The following is a description of a gene set: Human Gene Set: MIR6752_5P studied in species Homo sapiens Genes predicted to be targets of miRBase v22 microRNA hsa-miR-6752-5p in miRDB v6.0 with MirTarget v4 prediction scores > 80 (high confidence targets). from publication Chen Y, Wang X (PMID 31504780), and this is the list of marker genes: P2RX1, NDFIP1, MECP2, TBC1D30, LZTS3, PIP5K1A, PCYT1B, PRKACA, TBKBP1, RAB2A, ZBTB7A, RUNX3, PRKCG (protein kinase C gamma), TTC9, CETN1, RSPO4 (NCBI Gene Id 343637), ARHGEF1, PTCH1, RALY, DNAJB5, TMEM51, KLF12, RYR1, CAMK2A, FOSL1, MSR1, NECTIN1, MSN, ZC3H7B, DOK3, SFTPB, ZNF512B, DPY19L1, ZNF74, GPR3, DDAH1, UPK2, RRP7A, SLC43A2, FXR2, BCL11B, B4GALT7, SEMA6A, DMTN, NFIC, FOXP4, LHFPL1, CNIH2, IGF2, MNT, MYH14, PPP6R1, TPBGL, ABLIM3, CYB5R3, HOXA9, MEF2D, RAB3A, DAGLA, CELF5 (CUGBP Elav-like family member 5), HIP1, RC3H1, OLFM2, BCL2L13, KLC2, ASIC1, RPP14, ZSWIM4, PSD4, VPS13D, CNNM1, ARID3B, CITED2, RASL10B, MIER2, CTCFL, SLC25A4, KMT2D, ZFR2, DLK1, PTPRD, KMT5A, KCNIP3, GGA1, SYNGAP1, B3GNT7, LIN7C, IQSEC2, PUS10, NEURL1B, EFNA5, SEPTIN9, GSDMA, LEF1, FIZ1, FOXO6, PADI2, SMARCD1, CDC25A, CNPY2, KDM6B, YWHAH, PDF, PHOSPHO1, TRIM58 (NCBI Gene Id 25893), OTUB1, CNIH4, ADGRB1, FOXA2 (forkhead box A2), CYP2W1, SCRT2, NECTIN4, KCNK3, HYOU1, SPNS2, U2AF1L4, PIN1, WDR33, POLR2F, RARA, ZNF385A, TLDC2